Given this list of marker genes LYN (LYN proto-oncogene, Src family tyrosine kinase), GP1BA, ITGA10, ADAMTS13, ITGA2, COL1A1, GP1BB, ITGA1, ITGB1, VWF, FCER1G, FYN, COL1A2, GP6, GP9, GP5, here is a description of the gene set: Reactome Pathway: Platelet Adhesion to exposed collagen studied in species Homo sapiens part of: Hemostasis Initiation of platelet adhesion is the first step in the formation of the platelet plug. Circulating platelets are arrested and subsequently activated by exposed collagen and von Willebrand factor (VWF). It is not entirely clear which type of collagen is responsible for adhesion and activation; collagen types I and III are abundant in vascular epithelia but several other types including IV are present (Farndale RW 2006). Several collagen binding proteins are expressed on platelets, including integrin alpha2 beta1 (α2β1 or ITGA2:ITGB1), GPVI, and GPIV. ITGA2:ITGB1, known on leukocytes as VLA-2, is the major platelet collagen receptor (Kunicki TJ et al., 1988). ITGA2:ITGB1 (α2β1) requires Mg2+ to interact with collagen. The activation of ITGA2:ITGB1 (α2β1) is modulated by the activation of integrin alphaIIb beta3 (αIIbβ3 or ITGA2B:ITGB3), which functions as a platelet receptor for fibrinogen and VWF (van de Walle GR et al., 2007). The I domain of α2 (ITGA2) subunit binds a collagen motif with the sequence Gly-Phe-Hyp-Gly-Glu-Arg (Emsley J et al., 2000). Binding of collagen to ITGA2:ITGB1 (α2β1) generates intracellular signals that contribute to platelet activation. These interactions facilitate the engagement of the lower-affinity collagen receptor, GPVI (Tsuji M et al., 1997), the key receptor involved in collagen-induced platelet activation. The GPVI receptor is a complex of the GPVI protein with a dimer of Fc epsilon R1 gamma (FceRI gamma). The Src family kinases Fyn and Lyn constitutively associate with the GPVI:FceRIgamma complex in platelets and initiate platelet activation through phosphorylation of the immunoreceptor tyrosine-based activation motif (ITAM) in FceRI gamma, leading to binding and activation of the tyrosine kinase Syk. Downstream of Syk, a series of adapter molecules and effectors lead to platelet activation. VWF circulates in plasma as a multimeric molecule that senses hydrodynamic shear forces in the bloodstream (Reininger AJ 2008; Mojzisch A & Brehm MA 2021). Upon vascular injury, circulating VWF binds to subendothelial collagen, which becomes exposed to the flowing blood (Bergmeier W & Hynes RO 2012; Colace TV & Diamond SL 2013). Upon binding to collagen, VWF becomes anchored to the damaged surface. Shear forces then induce conformational changes to mechanosensitive VWF causing the bound VWF to stretch and unfold (Li F et al., 2004; Schneider SW et al., 2007; Fu H et al., 2017). VWF unfolding leads to exposure of the A1 domain to allow binding to glycoprotein Ib α (GPIbα, encoded by GP1BA), a subunit of the platelet surface GPIb:IX:V complex (Dumas JJ et al., 2004; Ju L et al., 2013). Shear-induced aggregation is achieved when VWF interacts both with exposed collagen and platelets to initiate platelet adhesion to vascular injury sites. The interaction between VWF and GPIb is regulated by shear force; an increase in the shear stress results in a corresponding increase in the affinity of VWF for GPIb.